Given this list of marker genes SLC5A3, IL16 (NCBI Gene Id 3603), HSPA1A, KDM3A, RAB3GAP2, BANP, FAM200C, TSPAN12, EPOR, KLF2, CCR6, RSBN1, YEATS2, JAK2, RGS3, INSIG2, AURKA, STK38L, ST8SIA4, SLC35A1, ATP10D, APOLD1, HERC2P9, GPR15, ZNF248, MLH3, GOLPH3L, APAF1, STK38, S100PBP, ATF7IP2, KIF20A, HSPA1B, TMCC1, CENPA, BCL11A, BCL2, JRKL, VGLL4 (vestigial like family member 4), RIPOR2, HILPDA, TTC9, CCNG2, PSRC1, PMS1, PLA2G4A, ZBTB32, MORC2, DIPK1A, DEPDC1, ZNF280D, SLC2A3, ADM, MSMO1, RAD54B, BBS10, KCNN3, here is a description of the gene set: Radiation exposure through environmental, medical, and occupational settings is increasingly common. While radiation has harmful effects, it has utility in many applications such as radiotherapy for cancer. To increase the efficacy of radiation treatment and minimize its risks, a better understanding of the individual differences in radiosensitivity and the molecular basis of radiation response is needed. Here, we integrated human genetic and functional genomic approaches to study the response of human cells to radiation. We measured radiation-induced changes in gene expression and cell death in B cells from normal individuals. We found extensive individual variation in gene expression and cellular responses. To understand the genetic basis of this variation, we mapped the DNA sequence variants that influence expression response to radiation. We also identified radiation-responsive genes that regulate cell death; silencing of these genes by small interfering RNA led to an increase in radiation-induced cell death in human B cells, colorectal and prostate cancer cells. Together these results uncovered DNA variants that contribute to radiosensitivity and identified genes that can be targeted to increase the sensitivity of tumors to radiation. species: Homo sapiens Human Gene Set: SMIRNOV_RESPONSE_TO_IR_2HR_DN from publication Smirnov DA, Brady L, Halasa K, Morley M, Solomon S, Cheung VG (PMID 21844125) Genes down-regulated in B lymphocytes at 2 h after exprosure to 10 Gy dose of ionizing radiation.